Given this list of marker genes DEDD2, HSBP1, UBB, TNFRSF21, RLN1, COL4A6, DNAJB1, FKBP4, CRYBA4, HSPA2, HSF1, MRPL18, EP300, HSPB1, HSPA1A, DNAJB6, HSP90AB1, HSPA1B, HSPH1, HSPB2, HSPA1L, GML, PTGES3, SERPINH1 (serpin family H member 1), HSPA6, HSPA8, CREBBP, HSP90AA1, here is a description of the gene set: Human Gene Set: REACTOME_ATTENUATION_PHASE Attenuation phase species: Homo sapiens